The following is a description of a gene set: species: Mus musculus Mouse Gene Set: chr7B2, and this is the list of marker genes: Chst8, B230322F03Rik, Zfp507, Gm12784, Gm35611, E230020A03Rik, Slc7a9, Tdrd12, Rhpn2 (rhophilin, Rho GTPase binding protein 2), Gm45095, Gm28077, Gm25922, Pdcd5, 6720469O03Rik, Gm12781, Ankrd27, Pepd, Kctd15, Gm9211, Faap24, Rpl17-ps9, Lrp3, Cep89, Gm38991, Wdr88, Gm18558, Rgs9bp, Nudt19, Gm24505, Gm12780 (NCBI Gene Id 668460), Dpy19l3, Cebpg, Gm18254, Gm28075, Gpatch1, Tshz3, Gm28076, Cebpa, E130304I02Rik, Gm35665, Slc7a10 (solute carrier family 7 (cationic amino acid transporter, y+ system), member 10)